Given this list of marker genes SNX10, SNCA, MTSS1, HBEGF, EPB41L4B, SLC7A8, NMU, HES1, CA2, KCNN4, ADAM8, GPM6B, LYN, CDCP1, MIA, S100A14, CRYBG1, SERPINB13, ROBO1, LIMK2, CADM1, C1orf116, IRF6, S100A2, DUSP10, COL17A1, KRT18, KRT6A, LAMB3, ANO1, SH2D3A, SPRR2A, CD24, DSP, PDPN, HOOK2, CTSC, MAP7, KRT81, PLXNB1, BMP2, DSC3, TACSTD2, SCNN1A (sodium channel epithelial 1 subunit alpha), FZD5, DAPP1 (NCBI Gene Id 27071), TMEM51, CTSV, ALS2CL, MYO1D (NCBI Gene Id 4642), PRKCZ, DDR1, LGR4, SLC7A5, MCTP2, TMPRSS4, IFIH1, ALOX15B, TINAGL1, CXCL1 (C-X-C motif chemokine ligand 1), PCDH7, OCLNP1 (OCLN pseudogene 1), INAVA, PTPRF, IGSF3, CSTA, ANK3, KRT16, ARHGEF5, LAMC2, CD24P4, KCNK1, COBLL1, CNTN1, ARAP2, IL18, CYP4F11, HERC6, SEL1L3, ARHGEF4 (Rho guanine nucleotide exchange factor 4), GCLC, ZC3H12A (NCBI Gene Id 80149), CASP1, ARG2, CAMK2B, JAG2, HOMER1, CEACAM6, LGALS7, MMP1, FGFBP1, CDH3, ERVMER34-1, LYPD3, CA9, KCNG1, CYP27B1 (cytochrome P450 family 27 subfamily B member 1), CXCL8 (NCBI Gene Id 3576), MYO18A, OVOL2, NRCAM, G0S2, ADIRF, FERMT1, GALNT3, ALDH1A3, CXADR, S100A7, BDKRB2, RIGI, PIP4K2C, XDH, RIPK4, HS3ST2, DUSP6, TFCP2L1, ABLIM1, TRIM29, LPCAT4, CST6, GALNT6, MISP, PLAU, EDN1, LPAR2, MREG, SLC35G2, CEACAM1, QPCT, RHBDF2, GRB14, F3, CLDN7, SPCS3, CCN6, PRRG4, AQP3, VDR, MAST4, CNTNAP2, FGFR3, CCNG2, ITM2A, TNFRSF25, SLC12A8, NAV3 (NCBI Gene Id 89795), ARHGAP25, EHF, CORO2A, SERPINB2, ZNF185, SFN, IL13RA2, SERPINA3, IVL, KIAA0040, LAMA3, TIMP3, ESRP1, JUP, RIMS3, CD24P2, SLPI, GM2A, KRT17, MAOA, TNFRSF6B, FST, MTARC1, PTAFR (NCBI Gene Id 91527), EREG, BIK, RHOD, SMPDL3B, PLK2, SEMA3F, LY75, ABCA12, MYO1E, ARL4C, KLK11, NBEAL2, TMPRSS11E, PPL (NCBI Gene Id 5493), DUOX1, SLC2A3, ARHGEF3, CSF2, MCOLN3, HLA-DOB, PERP, KLK8, IL1RN, SPRR1B, CSF3, CDH1, SIRPA, SPINT2, CELSR2, SPINT1, NFE2L3, CYB561, KIZ, CDK5R1, CDS1, CXCL3, SLC20A2, EPS8L2, GJB5, SLC6A15, RAPGEF5, ATP2B4, SYK, TSPAN13, RAB38, AP1M2, CCNA1, UPP1, ITGA6, KCNJ15, ERMP1, ANXA8, F11R (NCBI Gene Id 50848), ADTRP, MST1R, ARTN, TMEM30B, GPR87, SPRR1A, PITPNC1, ITGA2, STEAP1, PAK6, APOC1, LAD1, SLC27A3, BIRC3, EPAS1, PRSS8, SUSD6, P3H2, SERPINB1, SORL1, MFAP5, KRT15, CYB5R2, TNFRSF21, AJAP1 (adherens junctions associated protein 1), RASSF9, CD44, TLR2, SOX9, CD82, MOB3B, KRT13, HDAC9, C3, HS3ST1, SEMA3C, KLF5, CLCA2, PLA2G4A, CREG1, FLNB (NCBI Gene Id 8413), CYP1A1, ST14, CTSH, TNFSF10, ITGB6, IL36G, HOXA1, TRIM34, GPRC5A, PSTPIP2, IER3, PRKCH, PKP3, SOX15, IL1RAP, CAMK2N1, HPSE, SCEL, DSC2, TGFA, TPD52L1, DMD, SERPINB3, CLIP4, MAPK13, ZHX2, AREG, ZBED2, STAC, SFRP1, CD55, ST6GALNAC2, ZDHHC13, EFNA1, LCN2, CBLC, SERPINB7, MTUS1, LPAR3, GNA15, CXCL2, SERPINA1, ST6GAL1, INHBA, SLC6A8, NRG1, DEPP1, RBM47, TMEM265, SLC1A3, SLC2A9, MALL, MARK1, CA12, ISG20, SERINC5, SLC31A2, MBP, KRT8, FGD6, CELSR1, KAZN, AKAP1, NDRG1, VGLL1, HOOK1, GJB3, GALNT14, SEMA3B, TMEM132A (NCBI Gene Id 54972), CRCT1, EPCAM (NCBI Gene Id 4275), SAA1, AGRN, BACE2, ZNF165, ARHGDIB, AMPD3, MMP9, FRMD4B, KLK10, RPS6KA1, TREM2, GRHL2, ICAM1, PTPN3, DSG3, ADGRE2, KRT14, S100P, FOS, OAS3, FAM169A, TAGLN3, FAT2, ADGRL2, DSCAM, BHLHE41, KLK7, RNF128, NCF2, RLN2, DDX60, IL1B, ST6GALNAC5, DSG2, CLDN1, PTHLH, SDC1, CLDN4, DIPK1A, CCND2, STAP2, L1CAM, RAB25, CCL20, EPS8L1, POPDC3, MYO1B, ESRP2, FZD3, EXPH5, ADGRA3, CORO1A, AKR1C1 (aldo-keto reductase family 1 member C1), TSPAN1, KRT5, CD83, CD1D, TFRC, PTGS2, INPP4B, ITGB4, KANK1, PTPRZ1, FGFR2, GNAL, IL1A, S100A9, SLC3A2, PTGES (NCBI Gene Id 9536), CKMT1B, GCH1, TP63, FEZ1, MPZL2, B4GALT4, VSNL1, DHRS1 (dehydrogenase/reductase 1), LTB, ATP12A, ABCG2, IFI30, P2RY2, FXYD3, MAP3K9, S100A8, WWC1, SPAG1, NUP62CL, ANXA3, MECOM, LIMA1, IL4R, PELI1, IL15RA, PARP12, SLC5A1, RAB17, B3GNT3, KRT6B, LRRC1 (NCBI Gene Id 80240), CD9, ARHGAP8, SEMA3A, LRP12, MMP10, TNFAIP3, TBC1D4, ADGRG1 (adhesion G protein-coupled receptor G1), PTPRE, LSR, NSG1, MGST2, TFPI2, PI3, EPN3, THBD, SDC4, ERBB3, TCF7L1, ADRB2, EPHA1, KLK5, SYBU, MYO5C, P2RX5, CYB5R1, RIMS2, ELMO3, FHOD3, FLRT3, TMEM40, MEAK7, IL1R2, IRX4, DST, SLC39A8, CWH43, here is a description of the gene set: Genes down-regulated in HMLE cells (immortalized nontransformed mammary epithelium) after E-cadhedrin (CDH1) knockdown by RNAi. Loss of the epithelial adhesion molecule E-cadherin is thought to enable metastasis by disrupting intercellular contacts-an early step in metastatic dissemination. To further investigate the molecular basis of this notion, we use two methods to inhibit E-cadherin function that distinguish between E-cadherin's cell-cell adhesion and intracellular signaling functions. Whereas the disruption of cell-cell contacts alone does not enable metastasis, the loss of E-cadherin protein does, through induction of an epithelial-to-mesenchymal transition, invasiveness, and anoikis resistance. We find the E-cadherin binding partner beta-catenin to be necessary, but not sufficient, for induction of these phenotypes. In addition, gene expression analysis shows that E-cadherin loss results in the induction of multiple transcription factors, at least one of which, Twist, is necessary for E-cadherin loss-induced metastasis. These findings indicate that E-cadherin loss in tumors contributes to metastatic dissemination by inducing wide-ranging transcriptional and functional changes. Human Gene Set: ONDER_CDH1_TARGETS_2_DN from publication Onder TT, Gupta PB, Mani SA, Yang J, Lander ES, Weinberg RA (PMID 18483246) studied in species Homo sapiens